The following is a description of a gene set: Human Gene Set: HP_ANOTIA species: Homo sapiens Anotia Complete absence of any auricular structures., and this is the list of marker genes: CDC45, ORC6, ORC4, FANCB, CDC6, DDX3X, CDT1, POLR1D, GMNN, SF3B2, POLR1A, HOXA2, ORC1, FANCL